The following is a description of a gene set: species: Homo sapiens part of: ABC transporter disorders In an ATP-dependent reaction, ATP-binding cassette sub-family A member 1 (ABCA1) mediates the movement of intracellular cholesterol to the extracellular face of the plasma membrane. Cholesterol associated with cytosolic vesicles is a substrate for this reaction. Under physiologocal conditions, the active form of ABCA1 is post-translationally modified (palmitoylated and phosphorylated), predominantly a tetramer and is associated with apolipoprotein A-I (APOA1). Defects in ABCA1 can cause Tangier disease (TGD; MIM:205400 aka high density lipoprotein deficiency type 1), an autosomal recessive disorder characterised by significantly reduced levels of plasma high density lipoproteins (HDL) resulting in tissue accumulation of cholesterol esters. Low HDL levels are among the most common biochemical abnormalities observed in coronary heart disease (CHD) patients. Reactome Pathway: Defective ABCA1 causes TGD, and this is the list of marker genes: ABCA1, APOA1